The following is a description of a gene set: from publication Chen Y, Wang X (PMID 31504780) Genes predicted to be targets of miRBase v22 microRNA mmu_miR_7674_3p in miRDB v6.0 with MirTarget v4 prediction scores > 80 (high confidence targets). studied in species Mus musculus Mouse Gene Set: MIR_7674_3P, and this is the list of marker genes: Ing4, Arhgap29, Sftpb, Gm2026, Fndc3a, Nipal1, Cxxc4, Gm6710 (NCBI Gene Id 627905), Brsk1, Rnf2, Zc2hc1b, Yy1, Atxn7l3, 4930579G24Rik, Or51e2 (olfactory receptor family 51 subfamily E member 2), Kdm2a, Tfap2b (NCBI Gene Id 98405), Shprh, Dnm3, Orai3, Zhx1, Bmp2k, Lrrtm4, Klhdc10, Ndc1, Abca8a, Ythdf1, Gm2a, Gm10220, Nectin1, Trib1, Hapln1, Cntnap2, Ptgr3, Ccny, Pdcd10 (programmed cell death 10), Ero1b, Eif4b, Flrt2, Senp8, Pgm2l1, Steap2, Smug1, Spam1, St3gal5, Lmo1, Dnah10, Zeb1, Fbxo43, Rnf168, Arhgef7, Cnbp, Srek1ip1, B3gnt9, Vipr1, Krt75, Nkx3-1, 5031410I06Rik, Gpatch2l, Npas3